The following is a description of a gene set: Human Gene Set: GAUSSMANN_MLL_AF4_FUSION_TARGETS_A_DN from publication Gaussmann A, Wenger T, Eberle I, Bursen A, Bracharz S, Herr I, Dingermann T, Marschalek R (PMID 17130830) Down-regulated genes from the set A (Fig. 5a): specific to cells expressing MLL-AF4 fusion protein alone. The reciprocal chromosomal translocation t(4;11) is correlated with infant, childhood, adult and therapy-related high-risk acute leukemia. Here, we investigated the biological effects of MLL.AF4, AF4.MLL or the combination of both reciprocal fusion proteins in a conditional in vitro cell culture model system. Several parameters like cell growth, cell cycling capacity, apoptotic behavior and growth transformation were investigated under physiological and stress conditions. Co-transfected cells displayed the highest resistance against apoptotic triggers, cell cycling capacity and loss-of-contact inhibition. These analyses were complemented by gene expression profiling experiments and specific gene signatures were established for each of the three cell lines. Interestingly, co-transfected cells strongly upregulate the homeobox gene Nanog. In combination with Oct4, the Nanog homeoprotein is steering maintenance of pluripotency and self-renewal in embryonic stem cells. Transcription of Nanog and other stem cell factors, like Oct4 and Bmi1, was verified in biopsy material of t(4;11) patient cells which express both reciprocal t(4;11) fusion genes. In conclusion, the presence of both reciprocal MLL fusion proteins confers biological properties known from t(4;11) leukemia, suggesting that each of the two fusion proteins contribute specific properties and, in combination, also synergistic effects to the leukemic phenotype. studied in species Mus musculus, and this is the list of marker genes: AGMO, FKBP10, SOD3, MLIP, SLC4A10, COL2A1, ITGB5 (integrin subunit beta 5), COLEC10, SEMA3C (NCBI Gene Id 222200), DCC, FBXO2, AARS2, NAT1, ASRGL1, RACGAP1, PPM1L, PGBD5, ACOT2, PARM1, HLA-DMA, MYO1D, CXADR, ERLEC1, MACC1, CD59, SLAMF9, SLC2A3, NTN4, GALNT13, KLF2, CSDC2, ATF3, ENPP2, HIRA, TENT5A, LRRN4CL, PLEKHA7, TSPAN13, CDH17, TACC1, DDX18, LOXL4, ALDH1A1, EFNA5, SH3BGR, VAV3, CABLES1, WSCD2, CPEB2, CEP72, SLIT3, SDSL, PYCR1, ENDOD1, ESR1, LMF1, NPTXR, APLP1, LRATD2, C3orf38 (NCBI Gene Id 285237), COL19A1 (NCBI Gene Id 7950), C1QTNF3, GTSF1, LAMA5, RASGRP3, ITIH5, EPPK1, SCARB2, FAM107A, CYP2C18 (cytochrome P450 family 2 subfamily C member 18), CAMK4, HOXD13, KCNMB1, TGFB2, UPK3B, LYZ, B4GALNT4, LCP1, SPEF2, PCOLCE2, KRTAP1-3, PDE4B, IQCG, AHRR, PHLDA2, HLA-B, ZNF746, C16orf89, SLC22A18, SEMA3D, WNT7B, ANKS3